Given this list of marker genes Lsm11, Snrpd3, Snrpb, Snrpf, Snrpg, Snrpe, Lsm10, Snrpert, here is a description of the gene set: Mouse Gene Set: GOCC_U7_SNRNP species: Mus musculus A ribonucleoprotein complex that contains the U7 snRNA and is required for the 3'-end processing of replication-dependent histone pre-mRNAs.